The following is a description of a gene set: species: Homo sapiens Nuclear import of Rev protein Human Gene Set: REACTOME_NUCLEAR_IMPORT_OF_REV_PROTEIN, and this is the list of marker genes: NUP42, NUP153, NUP85, RANBP2, NPM1, NUP43, NUP62, NDC1, NUP37, RAN, RAE1, NUP188, NUP54, NUP50, NUP214, AAAS, NUP210, NUP107, NUP58, KPNB1, NUP98, SEC13, NUP155, NUP35, NUP88, POM121C, NUP160, TPR, NUP133, NUP205, SEH1L, RCC1, POM121, NUP93